Given this list of marker genes SLC30A1, MCUB, PACSIN3, FKBP1B, AMBP, TNNI3, YWHAE, MICU1, CALM1, CALM2, ITPR1, GSTM2, STX1A, PHPT1, here is a description of the gene set: Human Gene Set: GOMF_CALCIUM_CHANNEL_INHIBITOR_ACTIVITY studied in species Homo sapiens Binds to and stops, prevents, or reduces the activity of a calcium channel.